The following is a description of a gene set: Genes containing one or more binding sites for (MEF2C) in their promoter regions (TSS -1000,+100 bp) as identified by GTRD version 20.06 ChIP-seq harmonization. species: Homo sapiens from publication Yevshin I, Sharipov R, Kolmykov S, Kondrakhin Y, Kolpakov F (PMID 30445619) Human Gene Set: MEF2C_TARGET_GENES, and this is the list of marker genes: CALML4, JPX, IL23R, SNORD116-8, SCN8A, RNA5SP205, CLPTM1L, ZNF747, PPP6R2, GCN1, ACAD9, TNFAIP3, SCARB2, DHRS4-AS1, SLC35B1, TSPAN10, MRPL21, MYO18A, RPL12P12, TRAJ6, COPE, PLCB1-IT1, ZNF3 (NCBI Gene Id 7551), UBE2O, SLC12A4, ERCC6L2-AS1, RN7SKP62, RMI1, RND1, PTPRO, SNORC, MCM6, THADA, SEC23A, BIN1, COL21A1, MRPS31P5, EDN2, TXNDC9, PTMA, GRM4, GSTCD, LINC-PINT, CIAO3, MT-TW, ZNF385A, TMA7B, DENND4B, RPS12, MALL, SYP, CTSC, HIVEP1, AKAP11, C3orf52, FLI1, NPC1, FAM3C, ITGB8, TTN-AS1, MT-TQ, ABCF2, PXK, ZBED5 (NCBI Gene Id 58486), GTF2B, CSK, IRF4, LINC01460, ENSG00000235978, SNAP25-AS1, PSCA, H2BC6, TGM2, MAGI2-AS1, ZPBP2, MVD, DAZL, SNX13, LINC01547, RPL12P28, LINC02289, AHSA2P, WDR36, TMX3, TRAV14DV4, NIBAN1 (NCBI Gene Id 63911), NAMPT, MIR3622B (microRNA 3622b), LGALS13, PDE3B, LZIC, CUL4A, ODAD3, MYO1C (myosin IC), SYNJ2, TMEM167B, ENSG00000215022, TANK, ADAMTSL4-AS1, RERE, ADCY5, CLEC16A, SCIMP, SORBS3, TSN, GTF2A1, MAGEA7P, PARP1, EPAS1, MTCO3P12, PLEKHG7, PPP1R18, HSD11B1, CASP8 (caspase 8), TICAM2-AS1, TRDMT1, FRG1HP, LINC01121, AOX3P, RNVU1-27, MTUS2-AS2, GNA15-DT, ALG1, TRIM13, GBA1, ZC3H3, IL4I1, ZNF106, NAP1L1, PAK6-AS1, ADAP1, CEP128, GALNT12, CREB5, ARHGAP31-AS1, LINC00898, MTND1P15, CD226 (CD226 molecule), KDSR, ALG10, BACE1, LMO4, KIAA0930, IL6R-AS1, SYNCRIP, TSC22D3 (TSC22 domain family member 3), KLF6, LRRC37A3, LINC01132, WASL, ENSG00000253177, SPEG, GMDS, RBBP6, STX4, PRKAB2, PBX1, NSA2, CCNT2-AS1, ITGB1, PDCD1, CTSA (NCBI Gene Id 5476), MYCT1 (NCBI Gene Id 80177), UBE2H, RNVU1-15, DAPK1, ZFAND5, PRRT1, RPL6P25 (NCBI Gene Id 401725), CLUH, CYP1B1, ADAT2, TNRC18, YARS1, CAPS2, IDH3B, CWC27, PLEKHM3, SH3GLB1, MKRN2, SUPT4H1, TATDN1, COX16 (cytochrome c oxidase assembly factor COX16), XIRP1, SNX11, HSPB1, OTUD4 (OTU deubiquitinase 4), CDKN2AIPNL, ADNP (NCBI Gene Id 256440), SNRPA1, CYP4V2, ZSWIM6, RN7SKP9, LINC01749, EPB41L4A-AS1, FRMD4A, USPL1, ELP2, POLR1A (RNA polymerase I subunit A), TUBGCP2, ERICH2-DT, NMNAT2, MKKS, LINC02898, RNU5D-1, DDX49, RN7SL172P, HSD17B3, BFAR, LINC00582, NAB1, RNU6-946P, SRSF3, ELAVL4, SLAIN1, MKNK1, HDLBP, CLIC5, CCL21, LACTB2-AS1, MACF1, TAF12-DT, STING1, LINC01348, LMBR1, FAM124B, HDAC9, ZBED1, VPS28, GAPDHP55, ARHGEF7, LNCATV, HBG1, BIRC3, TACC2, CNNM4, SPP1, PHIP, KRT20, SELENOF, CEP152, MIR1538, MT-RNR1, RPS19BP1, ITGB7, TLE4, DGKZ, IDH2-DT, MLEC, MAP3K12, MARCKSL1P2, FBXW11 (F-box and WD repeat domain containing 11), NCBP2AS2, ESR1, RAPGEF4, ENSG00000237429, TOMM6, ANAPC13, TSC1, SLC26A2, MS4A1, NUP42, SRRD, PTEN, LRRC14B, TRMT2A, VTRNA1-2, ABCD2, GABBR2, CLASP2, CERNA3, UIMC1, AOX2P, PSMC3IP, ZCCHC7, TNRC6B, CCZ1B, LINC00339, MTERF4, SORBS2, PLCL2, MT-CO1, PHACTR3-AS1, SMG6, LRRC37A6P, SNORA13, RNU6-354P, RSF1, VPS36, NRP2, NFE2L2, MT-ND6, H1-10, NTAN1, LINC01635 (long intergenic non-protein coding RNA 1635), RNU4-18P, OFD1, CACNA1A, MOG, SLC16A5 (NCBI Gene Id 9121), NPNT, ENSG00000249631, BBX (BBX high mobility group box domain containing), PSMC4, CDHR3, RABGGTA, RHEX, TPR, OSBPL9P3, FAM107B, STKLD1, IGKV4-1, MIDEAS, RPL21P100, FZD9, LINC01435, LINC00879, ACSF3, ZFHX3, ATP5MC2, MIR4437, TTC12, TMED1, ENPP1, EPS15, SLC25A16, TDP1, ZBTB37, MID1IP1-AS1, TGFBI, LINC00544, C12orf57, LINC02174, LINC01010, ARFGEF1, B4GAT1-DT, PACRG-AS2, DNM2, PWWP3A, ZPBP, CABLES2, TVP23A, BPNT1, CCT2, HOXA-AS3, EDEM3, RNU6ATAC11P, SEPTIN2, TCTA, KCTD5, RNU6-205P (NCBI Gene Id 106633815), DMRTA2, RRS1, TELO2, LINC02980, LINC01686, KCNK15-AS1, REEP2, LINC01805, C12orf42, PNPT1P2, LONP2, HHIP, NREP, PPP4R1L, TH2LCRR, LINC00973, MADD, KMT2A, GABARAP, USP48, WDR44, CEP85 (NCBI Gene Id 64793), RBMS3, SUDS3, B4GAT1, ANXA6, EEA1, ANKRD24, MAK, NCBP3, RORA-AS1, AURKBP1, MED24, GOLGA8M, CAVIN2-AS1, SCRIB, DNAJC27, ENSG00000254288, GATAD2A (NCBI Gene Id 54815), SNORA68B, TRPV2, BCL2 (BCL2 apoptosis regulator), FSD2, CYP11A1, FGF9, NDUFAF5, FHOD1, ADAMTS7P4, RFTN1, ETFRF1, DST, RCOR1, ACTR10, RABEP1, STYXL1, PPP2R5A, FLT3LG, NDUFV3, FAM174B, RN7SL408P, DLL4, TCTN1, BCAR1, RIPK2, SNRPA1-DT (NCBI Gene Id 120766138), MRPS18C, STPG1, CETP, MRPL58, PTPRC, REXO5, SLC7A11-AS1, KLLN, GRK2, ZNF503-AS1, AFTPH (NCBI Gene Id 54812), HMGA1, TLR5, PVT1, MAPKAPK5-AS1, EXOC1, ASS1, SNAPC5, C19orf38, SPTAN1, TRIM33, BPIFA2, SSBP1, GIN1, MPG, CCNT2, SACM1L, CARM1, CDC42SE2, SPINK14, MFSD12-AS1, RMDN2-AS1, CRELD1, CAVIN3, RN7SL692P, DAAM1, VPS37B, DPH5-DT, BMS1P4, DAXX, KLF11 (KLF transcription factor 11), TRIM38, HMGB4, WIZ, R3HCC1, RNF128, NAE1, LINC00635, MIR3934, TEDC1, LINC02977, IGF1R, BRD10, SNX1, GABPB1, SSBP4, MYLK3, KDM4B, HARS2, ANAPC10, PDS5B, RPL39P41, RPL26P20 (NCBI Gene Id 100271191), SPATA4, ADAMTS6, RPL7AP58, UHRF2, IRAG2, VLDLR-AS1, LINC01970, NDUFV2, ZBTB43, PHACTR3, HNRNPK, HSPH1 (NCBI Gene Id 9835), MEF2D, TBX4, RNVU1-6, G6PC3, SGMS1, STX16-NPEPL1, SREBF1, ACP3 (acid phosphatase 3), SFTA2, DENND5A, YY1AP1, JRK, PPT2-EGFL8 (PPT2-EGFL8 readthrough (NMD candidate)), MAD1L1, CLEC7A, CEP170, HEXD, GIMAP6, CD36, PSMA6, HINT1, ANKRD17, ZSCAN12, NR3C1, H2BC5, TOP3B, PIH1D2, SNHG32, TMEM170A, INPP4B, OSBPL9P2, TM7SF3, LINC01480, CORO7, LINC02090, NDUFAF1 (NCBI Gene Id 51103), ABCG1, SMAD3, SLC24A1, OLFM2, IL1R1, DGKD, CLASP1, ENSG00000268129, DENND5B-AS1, METTL25, PCMTD2, ARHGAP9, AFF3, LINC01234, DEGS1, MMP2, GFM1, BRF1, COMETT, TFRC, LINC01649, RGS3, RAD23B, SLC41A1, MACROD2, FEZ2, NEK8, TTC3P1, CSN1S1 (casein alpha s1), TBC1D19, JAG1, RN7SKP192, SPRYD4, RPAIN, RNU6-1061P, ZFP69B, ARFGEF1-DT (NCBI Gene Id 102724708), LIMK1, ICAM1 (intercellular adhesion molecule 1), TCEANC, KPNB1, CALM1, SHARPIN, ASB16, TAF12, IKZF3, EXOC7, ENSG00000275108, DHRS3, STX16, MIR4512, ROPN1L, BRF2, RB1 (NCBI Gene Id 92728), ERMN, MOK, MBTPS2 (membrane bound transcription factor peptidase, site 2), DDX18, ATXN7L3B, CEACAM3, MAN2C1, NIN, NEAT1, SYNPO2L, CAMK1D, NKAPD1 (NCBI Gene Id 55216), TGFB1I1, COL4A3, RBPJ, USP4, C19orf67, ARID1B (NCBI Gene Id 645070), HDAC5, MTPN, CCAR2, POLG2, FOXP1, SLC17A5, PPT2, PRPF8, RSAD2, HMGB1, RHOA, GLUD1P3, TBC1D10A, LRIG1, ERCC5, POLR2A, SOX2-OT (NCBI Gene Id 347689), SLC22A7, ZNF346, RRAGC, ADPGK, NKIRAS1 (NFKB inhibitor interacting Ras like 1), UBALD2, PSD4, LINC02922, SAMD4A, MED6, HAL, GRK4, BTG1, LTV1P1, GPR18, IDH3B-DT, ZGPAT, RABGAP1L-AS1, ATP5MGP8, TSPAN7, REEP1, TRAC, DZIP1L, SRGN, RPS20P4, SNX14, RRP1B, HMG20A, FGD6, CLTC, DOCK4-AS1, ATP6V1D, H3P35, LAMP1, ZNF287, DEPDC5, GSN, LINC02426, VEZF1, MIR4498, CRTC2, NIPSNAP2, BNIP1, MCUR1, CA5B, B4GALT7, SEC13, ARHGEF2-AS1, PCNP, TSR3 (NCBI Gene Id 64721), ZNF165, SDCCAG8, VDR, DOCK7, PAK6, LINC02938, MRPL40, IGHMBP2, KLHL18, ANKRD55, ROMO1, ATR, DIP2B, SLC16A1, ZNF721, TSPAN18, ATF7IP, PIGA, GALT, SLC27A2 (solute carrier family 27 member 2), SNAP23, TNS3, ADGRD1-AS1 (ADGRD1 antisense RNA 1), ATP6V0D1, PRKAG2, RTF2, ADAMTS4, PITRM1, EYA2, EFNA5, SPIB, LINC00240, MPP7, DEPP1, LINC02901, AP2A2, CCDC88A, ZNF609, NFKB2, SNHG12, RNU2-63P, ENSG00000254718, DTWD2, COA6-AS1, GFI1B, SLC25A3P2, SEMA4B, FAF1, TMEM35B, GORASP2, MCL1, ACTA2, KCTD2, VWA7 (NCBI Gene Id 80737), NFS1 (NFS1 cysteine desulfurase), AGPAT3, TTC12-DT (NCBI Gene Id 124902814), TNRC6C, ENSG00000236846, HNRNPM, TSGA10, ITSN1, TP53, STX6, DOT1L, TMEM237, PIGG, HARS1, SMARCA2, SIK2, METAP1, BTG1-DT, WDFY1, PRICKLE1, TNFSF14, POLDIP3, LITAF, CENPE, ACSL1, SBNO1 (strawberry notch homolog 1), SMIM14, STRIP1, SVIL, UBAC2, UBE2E2, VLDLR, NMNAT1, CHAF1A, TSEN54, TFAM, CDK17, ETV5-AS1, LINC01852, ARHGAP42-AS1, AP2B1, CENPJ, MAP4K3, ENPP3, MTHFD1L, TBCD, TNIP2, WHSC1L2P, MALAT1, SCAMP2, WDR1, TBL1XR1, G6PD, ATG5, STAT3, RNU6-351P, LRRK2, ACKR3, COPS4, LRATD2, ENSG00000224935, ENTR1, IL21R, ENDOU, GNAS, SCYL2P1, BHLHE40, EPC1-AS2 (EPC1 antisense RNA 2), EIF2B4, PPIL3, CPNE2, RARG, CLEC2D, PFKL, MOB3A, IMMP2L, CDK5RAP3, SLC16A13, SECTM1 (secreted and transmembrane 1), IFIT1, WDR7, ARHGAP10, ZNF213, CEP44, XXYLT1, DECR1, MTSS1, ITPR1, PLK1, SLC38A4-AS1, NFKBIA, DUSP16 (dual specificity phosphatase 16), SPRY2, AMOTL2, ESF1, FLOT1, FLJ38576, PLEKHA4, CLN3, SERPINA13P, SLC35A1, PHF24, PLD3, DUS1L, STARD10, SYT7, SDE2 (NCBI Gene Id 163859), RRS1-DT, KRAS, BAG4, PGK1, TAS2R9, GARS1, GYS2, GNE, SLC22A23, COLCA1, ZMAT2, PSMD11, SLC15A4, AP3M2, TAS1R1, CYREN, EIF4BP9, ST3GAL1, TAF4, ADD3, ADGRD1, COMTD1, RNU6-485P, LINC02934, INTU, ARAP2, ITPR1-DT, ASXL2, CRHR1, RNVU1-7, ARTN, RAB4B, POR, CFAP73, PLPP4, IL2RB, SDK1, MNDA, INTS14, UPF2, REV3L, UBA7, RNU4-2, ERGIC2 (ERGIC and golgi 2), NUDT5, PPIP5K2, WDR82, NPLOC4, FRG1CP, LTBP2, CAB39, SNX17, LIMD1-AS1 (LIMD1 antisense RNA 1), UBE2E2-DT, MKNK2, ARSG, DPF3, TIAM2, ANKRD50, CDC123, JADE1, UBIAD1, PAX1, FYTTD1, GSTZ1, PSPHP1, RAVER2, CCL3-AS1, SELENOH, GPBP1, MIR584, GAS7 (NCBI Gene Id 8522), OR2G6, FBXO34, MCM2, PAFAH1B3, CNTRL, LDLRAP1, LINC01923, PALS2, SURF4, EIF2S1, ATG16L1, ZER1, TRAPPC2, SMIM36, USP51, CCDC59, EEF1AKMT1, NIBAN3, ZNF746, CCDC77, ERICH3-AS1, NFYB, ATP2C1, PRKD2, MTCH1P2, TEDDM2P, LINC02392, TPST1, TMEM277P, BZW2, PF4V1, MNT, TSC22D1, CNTN4-AS2, KDM5A, CPNE8, CFLAR, LINC02642, NIF3L1, ISG15, ZNF843, TMEM41A, ABCE1, IL12A, ANXA3, C11orf68, FAM117A, HEMGN, COA1, ZNF169, ARMT1 (acidic residue methyltransferase 1), SNHG4, RILPL2, SNORD54, ACTB, MIB1, LINC00536, PRECSIT, DNAJC17, LNCRNA-IUR, MT-TT, LINC00158, ARHGEF9, RNU5B-4P, MIR520A, ITGAL, TARS1, MED4, ADAMTSL4, ARL6IP4, GLIS3, ENSG00000183154, RNVU1-4, BMS1, MKRN2OS, TCTN3, RSL24D1P11, MDH1, FRG1-DT, SLC22A5, CCL2, TCF7, GUSB, TXLNB, RNU1-78P, CEP250, PRKCE, HTATSF1P2, AGO2, WEE2-AS1, SPG7, JCHAIN, WDR89, ZNF527, CFTR, CDK14, BABAM1, RAPGEF6, BBOF1, RNVU1-34, TMEM138, AP4E1, RHBDF1, ALG10B, PNRC1, AAGAB (NCBI Gene Id 79719), OFCC1, RNVU1-3, ADCY10P1, PTPA, GAS5, SNORD101, IL12RB1, CCT4, BAZ2A, SIRT6, MYO9B, KLHDC10, B4GALT6, B3GLCT, ENSG00000257746, MIR3667HG, MEF2C, PABPC4, DDN, ZFYVE19, NSMCE3, SNORD107, ZFR, HDGF, ABI2, PXT1, FCN1 (NCBI Gene Id 2219), ZNF85, OTX2P2, FRA10AC1, SNF8, FERMT3, PROSER2, ZNF768, RAB31, RAD21, N4BP2, NSFL1C, GJA3, MAGOHB, NLRP4, ITGB8-AS1, LINC02354, CLEC14A, RNVU1-14, GCLM, MTUS2, ZCCHC8, SMARCD2, SPHK1, RNU4-70P, COX20P2, ZNF276, MARF1, TEFM, CIB2, APH1B, ASXL1, ARVCF, ST7, RNVU1-28, KLHL8, KCTD20, NR2C1, SLC39A3, TARS1-DT, GNPTG, LINC01366, PARN, VARS2, TMEM242, TRAF4, ETV6, LINC00265, CD164, UBE3A, SARNP, ENSG00000266401, TNFAIP8, LY9, CRK, MAF1, ZFAT, STXBP1, PAG1, PDE8A, PTPRU, IER3-AS1, ZFP90 (ZFP90 zinc finger protein), LINC02608, ZNF213-AS1, ENSG00000188897, PNISR, RIGI, COIL, SYT9-AS1, CENPU, HPS4, MTF2, SAR1B, CNR2, SYS1-DBNDD2, AKR1B1, NOXA1, MIR8074, MT-TP, PITPNM2, ST6GAL1, FRY, NCOA3, SLC45A3, STOML1, PLCL2-AS1, LRRC8D, NACC1, PCDHGC5, COG5, CEBPA, METTL9, TDRD7, ADI1P3, DCLRE1B, GABPB1-AS1, HIRA, ATP6V0A2, ZNF236-DT (NCBI Gene Id 100131655), CCR2, EXOSC3, MIR3190, STEEP1, ENSG00000249236, ARHGEF2, DCAF17, SCAMP5, NINJ2-AS1, ATG7, RPL27, RGL2, COX7CP3, RPL15, PMCH, RPS29P4, WDR24, C18orf21, DENND2B, RHBDF2, ZNF790-AS1, ZNF581, VPS16, AQP1, SMCO4, ERLIN2, ALK, RNASEH2C, KBTBD6-DT, BTF3L4, NR4A2, EHD4-AS1, TACC1, BARD1, MT-TF, CMPK2, NADK, GEMIN8, IL6ST, SLC44A1, SHLD1, SERP1, POMT2, ESM1, SIRT1, NMUR1, EGR2, RINT1, OTUD5, RB1-DT, ENSG00000212249, OGFOD3, UBR4, FNTA, CAST, MIR1284, ATF3, LINC02334, RPL38, MAP1LC3B2, AP3S2, PPCDC, MIR9-3HG, ZNF821, TBL1X, ALKBH2, TRMU, PLA2G4C, LIMS1, PRKCZ, BCL9L, DUSP10 (dual specificity phosphatase 10), U2SURP, CDKN2AIP, ZNF443 (zinc finger protein 443), GARS1-DT, MIR652, LZTFL1, RANBP1, WRAP53, JMJD1C (jumonji domain containing 1C), FHL1, MRPL44, RASA1, SP2, ENSG00000253165, DNAI7, ENSG00000250075, TSPYL1, RPS28, LINC02541, CYBB, DRAP1, PRR11, AKAP13, ZNF580, RBM47, DPRXP3, KIF21B, DTD1, SRRM3, SEMA7A, DMXL2, BCKDHB (NCBI Gene Id 594), ERRFI1-DT, MLH1, EPOP, DNAJA3, KIF6, LIMA1, PPP1R16B, ARID2, BCAP29, ABCA7, DOCK2, RAPGEF1, OXTR, RASGRP3, ZNF687-AS1, ZNF529, STAP2, GTPBP2, PPP4R3B-DT, EIF4E2, ZNF687, INPPL1, LINC02709, BMS1P4-AGAP5, NEK6, CXCL12, PAM, KBTBD2, PEMT, TMEM242-DT, OR5H1, EMC7, BANK1, FAR1-IT1, COL12A1, ADGRG1, GOLGA7, NFX1 (NCBI Gene Id 94733), FNBP1L, RBM45, DUSP8, SIRPB2, NDUFS4, HEBP2, FOXN3, TARS2, ARHGAP42, BEND6, MIR7845, ZNF23, GASK1B-AS1, EFHC1, PELI2, GFI1, ZNF770, MT1E, DSTYK, FAR2, BTBD17, ARL8B, GPR55, PLB1, LINC02132, LINC02026, COL16A1, KAT6A, SORBS1 (NCBI Gene Id 80057), TEKTIP1, WWOX, RNU7-27P, ZNF174, ANKRD34A, TMED9 (NCBI Gene Id 96645), SAE1, CEP135, BCAS4, IST1, ENSG00000230226, LINC02615, AZIN2, KBTBD6, GNG12, S100A7A, CALCOCO1, LMNA, ZFP30, MIR510, SLC2A13, MON1B, SPATA31D2P, KCTD17, DCUN1D4 (defective in cullin neddylation 1 domain containing 4), INTS15, NPM1P7, EIF3J-DT, UBE2F, ATXN1L, SNHG14, GRSF1, MATR3, BUB1, HSD17B12 (hydroxysteroid 17-beta dehydrogenase 12), SEMA3E, GTF2H4, ZC3H12C, LYN, PHF12, EEFSEC, COPS7B, KPNB1-DT, C17orf99, HMGCR, ARID1A, PCID2, ERRFI1, TCF4, CD37, RPLP0P2, DNAJC3, SGCA, BUB1B, UBAC2-AS1, MRPS33, INTS12, SORL1, B3GAT1-DT, CSRNP2, ARHGEF12, KANSL3, CLK3, UNC5CL, IGSF10, ENSG00000254006, RMND1, CCNL1, CD44, NKTR, FBXO34-AS1, PYCR1, TPH2, EVL, NFAT5, IDH3A, MARCHF8 (NCBI Gene Id 220972), TUBGCP3 (NCBI Gene Id 10426), LAS1L, UST-AS2, INTS9, EPM2AIP1, RPP40, SCUBE2, SPAG5, ODAD2, ACBD4, GYS1, SH3BP1, C16orf95, SUB1, CCDC28A-AS1, SH3TC2-DT, AP4B1, VANGL1, CASKIN2, LATS1, TMPRSS9, TTLL9, RGS1, CRYL1, PTPN6, MED23, USP3, ANKRD40, SIGMAR1, HMGCL, RNU6-230P, ARHGDIB, ARFRP1, ASPSCR1, EIF4E, PARAIL, NNT-AS1, INO80B-WBP1, SCN3B, NAGPA, NCBP2, CBX8, PHLDB1, ITGA10, NR4A3, MIR4425, NRG4, SLC12A8, NOP14, H4C4, SLFN13, UBE2FP3, ODR4, DAZAP1, IL9RP6, IL3RA, UTRN, KEL, CTNNB1, LINC02989, FGR, DPY19L4, ZNF24, LRSAM1, DENND4A, TAB1, LINC00431, ALDH1A2, INO80B, ME1, RNU6ATAC34P (RNA, U6atac small nuclear 34, pseudogene), IQCH, HSF2BP, SEC61A1, IKZF2, EXD3, PSME3IP1, MIR620, RN7SL38P, MDM2, WNT10A, GNPTAB, PLEK, FRMD3, SLC37A3, ATXN7, MACORIS, ALS2, RPS15AP29 (NCBI Gene Id 100128863), HCG21 (NCBI Gene Id 414775, HLA complex group 21), PON1, MIR3142HG, NIBAN2, LIPT1, MTRF1LP2, MIR6083, TIMM8A, PHLDB2, PPP4R3B, KCNN3 (potassium calcium-activated channel subfamily N member 3), C11orf24, SLX9, MRPS30, REXO4, CC2D1B, ANKRD11, KIF13A, MRTFA-AS1, CERCAM, RBM28, WDR82P1, ADAM28 (NCBI Gene Id 27337), AFTPH-DT, ATP6V0D1-DT, WWTR1, MIR548AW, VIRMA-DT (VIRMA divergent transcript), TOB2, GABPA, ALB, NUMB, DMAP1, FOSB, PARD3B, ALPL, NEK3, NOL9, IPCEF1, PPP1R37, PPWD1, RN7SKP135, ZSCAN25, ENSG00000235480, PIK3C3, GASK1B, PFDN5, ZNF790, CXCL10, TXNDC12, DUSP22, WDR45, SNHG17, TFEB, RHEB (Ras homolog, mTORC1 binding, NCBI Gene Id 6009), KIF9, MADCAM1, NAGK, NAPA, DTNB-AS1, OR1X5P, AIRIM, STAG3L4, STK10, ZEB2, RNA5SP450, PEA15, HLA-DMB, GGNBP2, RPS7, ZNF747-DT, RNA5SP351 (NCBI Gene Id 106480764), PICALM, TRMT1, IFT122, LAMP3, AMPD3, KLF7, HMBS, NUF2, LINC02439, LRP1, NUP85, ZC3H6, CMSS1, MEF2A, FRG1, DDB2, TOMM40L, GRAMD1A, RPL11, HENMT1, GTF3C3, TBKBP1, PPP1R12C, FCSK, H2BC8, TNFRSF17 (TNF receptor superfamily member 17), GPR199P, C5orf15, IGLVI-70, PARP10, ARMC2, C17orf75, MRTFA, RNA5SP152, RNU6-60P, SYN3-AS1, SYCE2, SULF1, WASHC5, ZNF484, RPL29P20 (ribosomal protein L29 pseudogene 20), PDE4D, ZNF148, MTA1, TMEM9, ASB8, MELTF, WDR11, GRIN2A, ANKRA2, ARRB2, GSN-AS1, CEBPA-DT, RCC2, PEX3, POP7 (NCBI Gene Id 82671), ERG28, TNFSF13B, UBE2H-DT, TRAM1 (NCBI Gene Id 23471), AURKAIP1, ARHGAP45, RGS5, CLUL1, TMEM63A, RPL27AP9, UBTF, CHD9, ROCR, MIR29B2CHG, SLX4IP, IGHV3-63 (immunoglobulin heavy variable 3-63 (pseudogene)), PUM1, SMAD3-DT, HHEX, MEF2C-AS1, ENSG00000253214, ARPC5L, MAPKAPK5 (NCBI Gene Id 8550), PSMC1P8, VGLL4, UBE2NP1, MYO3B-AS1, MIR3913-1, PUM3, NBN, LINC01320, MIR142HG, STAT1 (NCBI Gene Id 6772), SLA, SYS1, RFESD, NTHL1, LINC02098 (NCBI Gene Id 105369564), PSMB3, SNX29, DENND1B, FTH1, ZSCAN16-AS1, COQ8B, LINC01353, PLD1, SUN1, UBE3D, MIR4733HG, STIM2 (NCBI Gene Id 57620), OMA1, YJU2, PSIP1, EIF5B, ATP1A1, PPFIBP2, BTRC, KCNJ11, SMIM14-DT, KLRK1-AS1 (KLRK1 antisense RNA 1), DOCK7-DT, TBC1D1, SYT17, DACT3, BUD23, CCL3L3, RPL26, TMC1, GPR107, DNAJB2 (NCBI Gene Id 3300), PTS, STIP1, PDE6D, DISP2, SEC14L1, PPP1R3B, TXN2, CCL3, ENSG00000232876, SEPTIN5, SCDP1 (stearoyl-CoA desaturase pseudogene 1), CIRBP, TIGD1, LCP1, HDAC7, DENND5B, OR3A1, ZSCAN32, ERBIN, B2M, DNPEP, ZNF839, CDKN2C, LZTS2, TRA2A, CTR9, RAB4B-EGLN2, NRXN1, RBM42, ABCA6, LINC02777, LINC00989, MADD-AS1, ERCC6L2, ITPKC, AVL9, NDST1, RPL37, HNRNPA1, TOR1AIP1, TMEM117, TMEM131, TMEM39B, ENSG00000255476, UBC, MT-TE, RPL7AP74, ATXN2L, C16orf89, ERC1, ARHGEF9-IT1, C1QL1P1, DDX21, LDLRAD4, AIP, HSP90AB1, SPATA2, ZBED5-AS1, ADAP2, LINC02940, HAUS8, COMMD10, KLF2, HILPDA, PPP1R3A, TRAJ7 (NCBI Gene Id 28748), PDE4B, LINC00511, SRSF2, ANKRD6, KDM3B, TBC1D4, CCNB1IP1, RMB8AP1, LINC03034, CCDC28A, KIAA0232, LINC00938, RPS20, EYS, COX5BP2, GBF1, LINC01023, ANXA11, SNORD52, MRPS31, RPL7P50, ATP6V1G1P6, CFLAR-AS1, LINC00944, ENSG00000283078, MYOF, NR4A1, PIPOX, CKB, EEIG2, NFXL1, SNHG31, ALOX15P2, AKT2, ARAP1, GTF2A1-AS1, VPS9D1, AKR1B15, MRPS30-DT, RIMS2, ENSG00000232581, LOXL2-AS1, ARF4, POLR2K, PLEKHN1, DNAJB12, PGM1, STIM1, MFSD11, PRKCSH, PRELID3A, HILPDA-AS1, RN7SKP175, IER2, S100A10, GRINA, WDR41, KRTAP5-AS1, ABHD3, ENSG00000252923, UTP15, ARHGAP44, IGFLR1 (NCBI Gene Id 79713), ERCC1, PASK, GAMT, SNORA75, NPTN, LARP7P4, LRRC63, SELENOT, CCL15, PCNT, GFM2, CAMTA1, ZMIZ1, CIAO2A, CCDC57, CDH17, FCHO1, C3, SDF2, NAV3, RIPOR2, YWHAH, ALG9-IT1 (NCBI Gene Id 100874303), ENSG00000232995, RHOB, TLCD1, CYCSP38, RAB18, SLC16A1-AS1, DGAT2L6, INSR, CITED2, ADGRL1, LSP1, MPHOSPH9, CDCA8, PRKCH, CMTR1, GDNF-AS1, ARHGEF6, PNOC, AAMDC, MLLT1, PSMB8 (proteasome 20S subunit beta 8), LRRK2-DT, FUOM, LINC01117, ICAM2, KRBA2, NUP88, LINC02909, PPM1A, KLHDC2, RAD51AP2, PER1, HEY2, WDR11-DT, NEURL2, SEPTIN9-DT, SMIM8, MFSD12, TLDC2, AFF1, KLF2-DT, CYB561A3, LINC01719, FCRLA (NCBI Gene Id 84824), DSE, SETD2, ERBIN-DT, MID1IP1, PCDHGC3, KDM1A, MANEAL, SEC22C, DNAJB13, MAPK1IP1L, DAB1, MTX2, RAC1P7, GRAMD1B, LINC03022, RNU2-34P, ADAMTSL4-AS2, ZMIZ1-AS1, MTIF2 (NCBI Gene Id 4528), MIR5188, TSEN15, SNRPE, DACT3-AS1